The following is a description of a gene set: species: Homo sapiens Reactome Pathway: Synthesis of very long-chain fatty acyl-CoAs part of: Fatty acyl-CoA biosynthesis Very long-chain fatty acids (VLCFA), ones with more than 20 carbon atoms, have diverse physiological roles, notably as components of ceramides in membrane lipids and as precursors of the eicosanoid hormones that play central roles in the generation and resolution of inflammatory responses. Saturated and monounsaturated VLCFAs can be synthesized by elongation of palmitic acid synthesized de novo or derived from the diet. Polyunsaturated VLCFAs are synthesized from dietary linoleic and linolenic acids - humans lack the desaturase enzymes to synthesize these molecules from stearate.<p>Chemically, the elongation process that yields VLCFA parallels the one by which palmitate (16 carbons) or stearate (18 carbons) are synthesized de novo from acetate. The starting fatty acid is activated by conjugation with coenzyme A (CoA-SH), condensed with malonyl-CoA to form a 3-oxoacyl CoA containing two more carbon atoms than the starting long chain fatty acyl CoA and CO2, reduced with NADPH to a 3-hydroxyacyl CoA, dehydrated to a trans 2,3-enoyl-CoA, and reduced with NADPH to yield a fatty acyl-CoA two carbons longer than the starting one.<p>The process differs from the de novo one in that the enzymatic activities resposible for each step are expressed by different proteins associated with the endoplasmic reticulum membrane, not by separate domains of a single multifunctional cytosolic protein. In humans, activation is catalyzed by one of five acyl-CoA synthetase long-chain (ACSL) enzymes, conjugation by one of seven elongation of very long chain fatty acids (ELOVL) proteins, reduction by one of two HSB17B estradiol dehydrogenases, dehydration by one of four protein tyrosine phosphatase-like / 3-hydroxyacyl-CoA dehydratase (PTPL / HACD) proteins, and reduction by one of two trans-2,3-enoyl-CoA reductase (TECR) proteins. Members of the four enzyme families differ in their tissue-specific expression patterns and in their substrate preferences (chain length, degree of saturation), leading to tissue-specific complements of VLCA.<p>Here the full two-carbon elongation cycle to form stearate from palmitate is annotated, as well as the activation and condensation steps for elongation of arachidonate, the 20-carbon unsaturated fatty acid that plays a central role in the synthesis of prostaglandins and related hormones., and this is the list of marker genes: HACD2, ELOVL6, HSD17B12, SLC27A3, HACD3, ACSL4, ACSF3, HSD17B3, ELOVL2, ELOVL4, ACSL5, ACSL1, ACSBG1, HACD4, ELOVL7, ACSL6, HACD1, TECR, ELOVL5, ACSBG2, ELOVL1, ELOVL3, ACSL3, TECRL